Given this list of marker genes MYL2, SPTA1, XYLT2 (NCBI Gene Id 64132), SLC4A1, MCM10, ACTC1, TNNI3, BAG3, ABCC6, PDGFRA, MYL3, XYLT1 (xylosyltransferase 1), FLNA, TTR, KIF20A, ENPP1, ANK1, SPTB, DES, CENPE, PIGT, TNNT2, EPB42, here is a description of the gene set: Restrictive left ventricular physiology is characterized by a pattern of ventricular filling in which increased stiffness of the myocardium causes ventricular pressure to rise precipitously with only small increases in volume, defined as restrictive ventricular physiology in the presence of normal or reduced diastolic volumes (of one or both ventricles), normal or reduced systolic volumes, and normal ventricular wall thickness. Restrictive cardiomyopathy species: Homo sapiens Human Gene Set: HP_RESTRICTIVE_CARDIOMYOPATHY